The following is a description of a gene set: Mouse Gene Set: GOBP_ATRIAL_SEPTUM_PRIMUM_MORPHOGENESIS The process in which anatomical structure of an atrial septum primum is generated and organized. species: Mus musculus, and this is the list of marker genes: Tgfb2, Sox4, Nsd2, Gata4, Acvr1